Given this list of marker genes HAMP, FTL, PKLR (NCBI Gene Id 5313), BCS1L, TMPRSS6, BMP6, SLC30A10, HJV, HFE, FTH1, TFR2, SLC25A38, SLC40A1, PIGA, STEAP3, here is a description of the gene set: Human Gene Set: HP_ABNORMAL_TRANSFERRIN_SATURATION Any abnormality in the serum transferrin saturation, which is calculated by dividing the serum iron level by total iron-binding capacity. Abnormal transferrin saturation studied in species Homo sapiens